The following is a description of a gene set: Mouse Gene Set: REACTOME_PLASMA_LIPOPROTEIN_ASSEMBLY_REMODELING_AND_CLEARANCE studied in species Mus musculus Plasma lipoprotein assembly, remodeling, and clearance, and this is the list of marker genes: P4hb (prolyl 4-hydroxylase, beta polypeptide), Lipa, Lpl, Furin, Ces3b, Prkacb, Angptl4, Clta, Zdhhc8, Apoc4, Prkaca, Ubc, Npc1, Mttp, Apoe, Ces3a, Pcsk9, Apoc1, Pltp, Apobr (NCBI Gene Id 171504), Ap2a1, Gpihbp1 (GPI-anchored HDL-binding protein 1), Nr1h3, Scarb1, Apoa4, Abcg1, Soat1, Abca1, Mylip, Ubb, Lcat, Apoa5, Lipc, Apob, Pcsk5, Alb, Uba52rt, Uba52 (ubiquitin A-52 residue ribosomal protein fusion product 1), Apoc2, Apoc2l, Vldlr, Bmp1, Ap2m1, Lipg, Npc2, Nceh1, Ldlrap1, Ap2b1, Rps27a, Apoa2, Cltc, Apoa1, Lmf1, Lmf2, Ap2s1, Nr1h2, A2m (alpha-2-macroglobulin), Angptl8, Soat2, Sar1b, Angptl3, Ap2a2, Pcsk6, Ldlr, Hdlbp